Given this list of marker genes PMVK, SLC19A2, BUB3, MRPL23, TIMM8B, CDK2AP1, TEX10, EHF, HSPE1, PPP1R14B, RBBP8, EIF3I, MRPL16, ST7, RRM2, SLC39A14, COX17, TTK, MCAT, MPZL1, BRIX1, FAF1, UAP1, RANBP9, STIP1 (NCBI Gene Id 10963), OGFOD1, DSCC1, FOXM1, PRMT3 (NCBI Gene Id 10196), ABHD5, RAD50 (NCBI Gene Id 10111), GSPT1, NABP2, NCAPH2, NAPG, CDKN3, PDCD5, DNAJA2, MCM2, UBR7, GMPS, BTG3, FAM98A, CENPM, ZMPSTE24, HAUS7, ACAT1, EAF2, MACIR, NDUFAB1, OLA1, TXLNGY, SNRNP40, UGGT1 (NCBI Gene Id 56886), RBFA, SLBP, TUBA1C, SHMT1 (NCBI Gene Id 9316), HADH, NUP37 (NCBI Gene Id 79023), RBM28, POLE3, AGPS, TIPIN, TFDP1, PUS7, KIF22, SOCS2, STMN1, NUP155, ESPL1, KDM1A, ARK2N, RCC1, TIMM13, GMNN, IL12RB2, RFC4, PELO, TRAP1, SLIRP, GLO1, RAD54B, DUT, BORA, SKP2, CCR4, CACYBP, EIF3J, TSFM, MRPL57, GNL3, GLMN, SPDL1, PKP4, LMNB1, ATP8B4, ELAC2, SLAMF1, FHL2, TYMS, PABPN1, PSMG1 (proteasome assembly chaperone 1), CNPY2, ZNRD2, FEN1, LRRC59, CDT1, DBF4, POLR2F, PRMT1, EXO1, ITPKA, GPR19, CKAP5, DHFR, NFYC, NCAPD3, PUM3, SNU13, THOC1, CXCR3, STK39, MYB, SAC3D1, THOC5, RAD1, PPA2, MAD2L1, TAF1A, SMC2, NMT1, ECT2, BATF3, ADGRA3, KLHL7, CCNA1, TAF5, TPM4, USP13, JMJD6, TRAF3IP1, PSMD12, NDUFAF4, CDC7, EZH2, NUFIP1, HMGB3, HBS1L, PER2, RABIF, MED6, BHLHE40, GEMIN6, MCM7 (NCBI Gene Id 4176), CENPN, UBE2E3, PLK1, PFDN2, RANBP1 (RAN binding protein 1), RFC5, MRPL40, GGH, CHCHD3, PSMD11, CENPF, GTDC1, SHMT2, DTYMK, KIF2C, CORO1B, MZB1, WDR12, LRPPRC, NCF4, SYT11, C9orf40, GOT2, GINS3, MELK, KIF23, NUDC, IPO5, GRPEL1, MCUR1, SMC4 (structural maintenance of chromosomes 4), DNM1L (dynamin 1 like), RAP1GDS1, EIF2S1, UBXN8, KIF3A, PAXIP1, VDR, KIF15, PCLAF, MYBL2, HCCS, CKAP2, LBHD1, PLAA (phospholipase A2 activating protein), here is a description of the gene set: Human Gene Set: GSE24634_TEFF_VS_TCONV_DAY5_IN_CULTURE_UP Genes up-regulated in comparison of untreated CD25+ T effector cells at day 5 versus untreated CD25- T cells at day 5. from publication Prots I, Skapenko A, Lipsky PE, Schulze-Koops H (PMID 21347372) species: Homo sapiens CD25+ regulatory T cells develop in the thymus (nTregs), but may also be generated in the periphery upon stimulation of naive CD4 T cells under appropriate conditions (iTregs). The mechanisms that regulate the generation of peripheral iTregs are largely unknown. We used microarrays to gain insights into the molecular program of extrathymic Treg development.